Given this list of marker genes NR6A1, BBS5, PIGR, KIAA1549L, KCNQ4, ACOT13, AKAP13, MORF4L2, RUFY3, NCS1, CD209, USP36 (NCBI Gene Id 80160), ST8SIA2, SGSM1, SRXN1, CLMN, ZNF483, KCNE4, PTMS, UBXN7, CALCR, ARL8B, KRT72, KHDRBS1, NID2, NRSN2, KSR2, MYH10, WASF3, RAB1A, FKBP1A, SEMA4G, DMBX1, PPP2R5A, RCAN2, ALPK3, MLXIP, PHF19, GOSR2, NSD2 (nuclear receptor binding SET domain protein 2), PIGK, SSX2B, TPRN, TNRC6B, MPDU1, TOMM7, NAA40, PDXK, GPATCH8, ATXN7L3 (ataxin 7 like 3), TMEM121B, SSX4, KCNB1, WASF2, PLEKHA6, PNKD, GABRA1, DDHD1 (DDHD domain containing 1), CDK14, SSX3, SSX2, TNNI1, BTBD8, TPCN1, OTUD7B, AQP1, N4BP1, KIAA0513, IL1RN, CNTN5, ATXN1L, ARL3, ZFR (zinc finger RNA binding protein), GSPT2, VOPP1, ONECUT2, NALF1, SLC41A1, FMNL3, FABP3, KANSL1, EFHD1, TUFT1, GRIN3A, KREMEN1, NR5A1, IDH3A, MICALL1 (NCBI Gene Id 85377), ST3GAL1, BSDC1, ATP1B2, MARK4, FAM168B, ERFE, ARK2N (arkadia (RNF111) N-terminal like PKA signaling regulator 2N), GLCE, C22orf23, TMEM127, ZNF546, USP37, HNRNPK, SDHD, GOT2 (NCBI Gene Id 2806), SLC2A4, AR, RRP36, CYP1A1, KDM7A, SKI, SEC31B, TLN2, GABBR2, LSM11, RGS8, RGL1, DCAF7, MMP16, AGO1, RHOXF1, MSI2 (NCBI Gene Id 124540), ZFYVE28, STMN4, POLR2F, KSR1, NECTIN1, SSX4B (NCBI Gene Id 548313), SCN2B, SNX27, GOSR1, PRRT2, LURAP1L, SSX1, ARL17A, FAM193A, NECTIN3, PCGF5, KLF12, ABLIM1, ZC3H6, LSM12, SSX5, NPLOC4, DTNA, OSBPL3, CCDC97, SLC25A42, NRBP1 (NCBI Gene Id 29959), GPR137, SENP8, ETF1, RRM2B, COPS3, TEF, TOMM22, SULT2A1, WDR19, FOXK1, CERS2, here is a description of the gene set: Genes predicted to be targets of miRBase v22 microRNA hsa-miR-2467-3p in miRDB v6.0 with MirTarget v4 prediction scores > 80 (high confidence targets). from publication Chen Y, Wang X (PMID 31504780) Human Gene Set: MIR2467_3P species: Homo sapiens